Given this list of marker genes ALK, here is a description of the gene set: species: Homo sapiens part of: Drug resistance of ALK mutants Reactome Pathway: ceritinib-resistant ALK mutants Ceritinib is a type I TKI that is effective against ALK driven cancers and is approved for treatment of NSCLC. Ceritinib is a second-generation TKI that shows activity against a number of crizotinib-resistant ALK alleles, however, resistance to ceritinib has also been documented. This pathway describes ALK mutants that are resistant to inhibition with ceritinib.